The following is a description of a gene set: Human Gene Set: REACTOME_SIGNALING_BY_ERYTHROPOIETIN Signaling by Erythropoietin species: Homo sapiens, and this is the list of marker genes: PLCG1, VAV1, HRAS, KRAS, PIK3CD, CRKL, LYN, SHC1, SOS1, PLCG2, EPOR (NCBI Gene Id 2057), STAT5B, PIK3CB, PIK3CG, JAK2, RAPGEF1, GRB2, NRAS, PIK3CA, GAB1 (GRB2 associated binding protein 1), PIK3R5, PIK3R1, IRS2, STAT5A, EPO